The following is a description of a gene set: The chemical reactions and pathways involving malonyl-CoA, the S-malonyl derivative of coenzyme A. Human Gene Set: GOBP_MALONYL_COA_METABOLIC_PROCESS studied in species Homo sapiens, and this is the list of marker genes: ACACA, NUDT19, MLYCD, ACACB, NUDT8, NUDT7